Given this list of marker genes E2F5, LIN9, LIN54, RBL2, TFDP2, MYBL2, LIN52, E2F4, CDK1, LIN37, TFDP1, HDAC1, RBBP4, E2F1, CCNA2, RBL1, here is a description of the gene set: In G0 and early G1, expression of E2F target genes such as Cyclin A, E2F1, CDC2 and MYBL2 is inhibited by complexes containing p130 (RBL2) and p107 (RBL1), respectively, and histone deacetylase HDAC1. Reactome Pathway: Transcription of E2F targets under negative control by p107 (RBL1) and p130 (RBL2) in complex with HDAC1 part of: G0 and Early G1 studied in species Homo sapiens